The following is a description of a gene set: studied in species Homo sapiens Human Gene Set: ACAACCT_MIR453 Genes having at least one occurence of the motif ACAACCT in their 3' untranslated region. The motif represents putative target (that is, seed match) of human mature miRNA hsa-miR-453 (v7.1 miRBase)., and this is the list of marker genes: ARPP19, TAL1, GLS2, FBXW7, ARID5A, VASP, SCARF1, PCDH8, NUDT17, AGO1, MYC, DDX11, CREBZF, CARNMT1, MANEAL (mannosidase endo-alpha like), NR4A3, RPS6KB1, KDM6A, BTBD7, MBD5, ITSN1, BCL11B, NHLH2, CNPY3, NIPAL2, GLRA2, ZFX, LAS1L, RAP2C, AMMECR1L, CCDC183, SNX27, MLLT3, IFIT1, CDK13 (NCBI Gene Id 8621), HSPD1, HOXA4, PKNOX2, MAFG, NCOA1, CDK10, SMIM21, BNC1